Given this list of marker genes PPP2R3C, GDF5, DVL1, PAH, BMPR1B, CANT1, KIF7, here is a description of the gene set: studied in species Homo sapiens Duplication of the distal phalanx of the thumb Human Gene Set: HP_DUPLICATION_OF_THE_DISTAL_PHALANX_OF_THE_THUMB Complete or partial duplication of the distal phalanx of the thumb. Depending on the severity, the appearance on x-ray can vary from a notched phalanx (the duplicated bone is almost completely fused with the phalanx), a partially fused appearance of the two bones, or two separate bones appearing side to side.